The following is a description of a gene set: from publication Hu X, Park-Min KH, Ho HH, Ivashkiv LB (PMID 16148108) Genes down-regulated in macrophages primed and then stimulated by IFNG: 3h versus 24h. studied in species Homo sapiens Human Gene Set: GSE1925_3H_VS_24H_IFNG_STIM_IFNG_PRIMED_MACROPHAGE_DN IFN-gamma transcriptional responses in control and IFN-gamma primed primary human macrophages, and this is the list of marker genes: ETS2, AURKA, MYCBP, LLGL1, UBE2B, IYD, LRBA, ASF1B, HIBADH, COCH, VPS4A, TUBA1B, TGFB2, KPNA2, NELFCD, CDC42EP4, ABL1, TAP2, PEX7, SPCS2, IL10, ANAPC16, COX17, COMMD5, FAM8A1, DHRS1, HMGB2 (high mobility group box 2), UROS, MAP2K4, C9orf40, KRT13, INTS14, ATP6V1G1, ST8SIA3, NHERF1, ENDOU, SPAG7, TFEB, SLC23A2, RGN, PRPS2, MED20, BPGM, HPCAL1, NUP35, AUH, THOC3, PDE1C, TOP2A, SSX2IP, NEK2, CASP6, TRIAP1, TPK1, CTDSP2, CLTB, CDC123, CTSV, BTG2, DHRS4, TAF8, ELAVL3, SBNO1, FLNA, FBLN2, GLA, CHTF8, NFYC, CDC42SE2, OAT, TM2D3, MDM4, CRKL, ZFP36, SLC23A1, UBE2S (ubiquitin conjugating enzyme E2 S), EIF1 (eukaryotic translation initiation factor 1), NFE2L2, CHMP3, BUB3, INTS5, AFF1, MAZ, HES6, CBX5, FRAT1, CCND3, SCP2, GSN, FUS, HNRNPU, POPDC3, PITPNC1, CD47, NSDHL, ING1, SRCAP, PRPF39, COX7A2L, NUP107, RRAGD, INSIG1, SLC6A15, ANKRD1, DNAI4, STRA8, DNAAF5, STMN1, CDKN2D, UGP2, P2RX1, CFAP20, ABCC5, UBALD2 (NCBI Gene Id 283991), CIDEA, QSOX1, MIDN, SLC11A2, AXIN1, ULK1, UBL5, RELL1, WDHD1, TBR1, LIG1, ADCY6, MIF, YIPF1, TNRC6A, CBX1, PRC1, TEX261, ZNF398, HNRNPH3, SEMA3E, MAD2L1, KCNJ15, GCLC, CD4, OPRL1, ZNF467, INTS7, SRP9, UCK1 (uridine-cytidine kinase 1), TMEM11, NID2, RAC1, APC, LIPA, NUP50, RAG2, PPIF, PGP, CD80, MIF4GD, PTPRF, PTCRA, RHOH, WDR48, NAA38, CDKN2AIPNL, ILVBL, SLC39A9, STK38, PCYT1A, GRPEL1, CAPN3, ENTPD5, POLA1, POLE3, MTCH1, CDK9, FAM216A, POM121, MELK, DNAJC9, SPA17, AADAC, TMEM266, TIMM23, HS3ST1, UNC50, MR1, AFF4, SMYD1, FBXO21, DNAJB1, BIRC5, CRYL1, WRNIP1, MTCP1, EXOSC4, RPL10, CDCA8, ZWINT, CRK, TCF4, IP6K1, ISCA2, DNMT1